The following is a description of a gene set: species: Mus musculus Mouse Gene Set: MIR_6960_5P Genes predicted to be targets of miRBase v22 microRNA mmu_miR_6960_5p in miRDB v6.0 with MirTarget v4 prediction scores > 80 (high confidence targets). from publication Chen Y, Wang X (PMID 31504780), and this is the list of marker genes: Sugct, Slc45a3, Alox15, Babam1, S1pr2, Poln, Pcnx1, Serpinb6c, Armcx3, Blcap, Sema3a, Mcidas, Lrrtm3, Mkx, Dcaf12, Ptpn3, Brdt (bromodomain, testis-specific), Dut, Usp44, Dhrs7b, Rsph4a, Med1, Lin52 (lin-52 DREAM MuvB core complex component), Stag1, Asb5, Sema5a, Usp33, Col5a2, Odr4, Vcl, Mex3c, Btaf1, Stim1, Sftpa1, Elavl2, Bptf, Ly6i, Sec61a2, Arhgap12, Bfar, Ccp110, Cimip2b